The following is a description of a gene set: Human Gene Set: REACTOME_DOWNSTREAM_TCR_SIGNALING Downstream TCR signaling species: Homo sapiens, and this is the list of marker genes: CD247, UBE2D2, PSMA3, CD3E, CDC34, UBE2V1, HLA-DPA1, PSMD12, FBXW11 (NCBI Gene Id 23291), TRAV8-4, CUL1, TRBV7-9, PSMD1 (proteasome 26S subunit, non-ATPase 1), PSMB6, HLA-DQB1, HLA-DRB1, NFKBIA, RELA, TRBV12-3, HLA-DRB3, PSMD11, PSMD8, RIPK2, PSMA5, PSMA7, PSMD3, HLA-DQA1, PSMB5, HLA-DPB1, LCK, UBB, PSMC6, TRAT1, HLA-DQB2, PSMD7, UBE2N, CD4, PSMC4, PSMC5, TAB2, HLA-DRB5, PIK3CB, TRAV19, PSMA4, PSMB3, BTRC, PSMD2, PDPK1, NFKB1, SKP1, CHUK, INPP5D, PIK3R1, PSMD13, PIK3R2, HLA-DQA2, PSMB4, UBE2D1, CD3G, PSMA6, PSMA1, IKBKB, PSMD6, HLA-DRA, PTEN, TRAV29DV5, PSMB2, TRAF6, IKBKG (NCBI Gene Id 8517), UBA52, PSMA2, CARD11, PSMC3, HLA-DRB4, MAP3K7, PSMD14, PSMB7, SEM1, PSMC1, CD3D, PSMC2, PRKCQ, BCL10, MALT1, PIK3CA, PSMB1, RPS27A, UBC, ADRM1